The following is a description of a gene set: studied in species Homo sapiens Human Gene Set: GOMF_STRUCTURAL_CONSTITUENT_OF_TOOTH_ENAMEL The action of a molecule that contributes to the structural integrity of tooth enamel., and this is the list of marker genes: TUFT1, AMBN, AMELX, AMELY, ENAM, STATH